Given this list of marker genes Chil5, Ctbs, Chit1, Pglyrp2, Spam1, Hyal1, Hyal6, Lyg2, Pglyrp1, Pglyrp4, Hexa, Tgfb1, Hexb, Lyve1, Fgf2, Slc9a1, Stab2, Chil3, Lyg1, Chia1, Ovgp1, Cemip, Cd44, Hyal2, Pglyrp3, Hyal4, Gusb, Hmmr, Sgsh, Hyal3, Chi3l1, Hyal5, Arsb, Idua, Chil6, Ids, Chil4, Galns, Cemip2, here is a description of the gene set: Mouse Gene Set: GOBP_AMINOGLYCAN_CATABOLIC_PROCESS The chemical reactions and pathways resulting in the breakdown of aminoglycans, any polymer containing amino groups that consists of more than about 10 monosaccharide residues joined to each other by glycosidic linkages. species: Mus musculus